The following is a description of a gene set: Human monocyte derived dendritic cells matured via galectin-1 or LPS. species: Homo sapiens Human Gene Set: GSE4984_GALECTIN1_VS_VEHICLE_CTRL_TREATED_DC_DN from publication Fulcher JA, Hashimi ST, Levroney EL, Pang M, Gurney KB, Baum LG, Lee B (PMID 16785517) Genes down-regulated in monocyte-derived dendritic cells: LGALS1 versus vehicle., and this is the list of marker genes: TMEM209, ALMS1P1, ROMO1, ZNF444, EMC2, DONSON, IMMT, ADAM17, MIR21, WDR1, UBALD2, TFRC, PRDM6, ZC3H4, AACSP1, ABAT, ALDH9A1, DUSP10, NR2F6, PIGP, ACOXL (acyl-CoA oxidase like), CFAP46, ACD, ZEB2, STAT4, MCM3, H2AC17, ULBP2, LSM6, BTBD10, AMMECR1L, STIL, ATAD2, PHF5A, ILK, TXNL1, TPTE2P2, NEFH, CARD9, SPAG5 (NCBI Gene Id 10615), PUS1, MCTS1, DIMT1, KNTC1, TOP3A, CALU, PPA1, ME2, CLIC4, PANK3, TRAFD1, SLC34A1, SHLD1, PPP2R5B, RAD54L, DCAF13, SYNGR3, APTX, CPOX, SEC23IP, UBA6, MRPL14, NAA25, CRYGN, CIAO2B, RSU1P2, POLR3K, MUS81, CCDC97, SPTSSA, CCDC117, SLC39A9, COQ7, SS18, PSMA5, FOSL1, STARD3, IL6ST, ADAM19, APOB, TOMM70, NACC1, HNRNPA2B1, ZDHHC13 (zinc finger DHHC-type palmitoyltransferase 13), TIAM2, SLC35A2, NDUFB5, TFE3 (NCBI Gene Id 8244), HOXC11, GCH1 (NCBI Gene Id 93984), RAB34, CDKAL1, DERL2, THOC6, PSME2, E2F3, FTSJ1, ALG2, LGI3, SRSF10, PPIL1, ALG5, RGMB-AS1, NUP50, PLAGL1, CHAC2, IPO8, DCTN2, TOMM40, GOLGA3, ARL4A, GID4, FLJ40288, PLXNC1, ANK2, KCNK15 (potassium two pore domain channel subfamily K member 15), SPIRE1, APOOL, MCOLN2, GINS4, NDUFV2, MRPL38, THPO, GNL3, LSG1, MAPK8, URGCP, POLD3, SPATC1 (spermatogenesis and centriole associated 1), CAB39, GPT2, SSR1, METTL1, SNHG12, GPN2, RHEB, TMED2 (NCBI Gene Id 10959), CREG1, DBR1, IPPK, MSH2, PPP1R10, ZC3H15, TSG101, MTO1, NOD2, RIMOC1, PANX1, CTR9, PRNP, RCAN1, HPS5, SIRT6, SHC1, SPSB2, UBE2A, KPNA2, MKX, JAM2, RNF212B, C10orf71, SFT2D1, RPN1, MYO16, RPA2, MON1A, MRPL27, SRRD, PEF1, SLC52A2, NSFL1C, SUZ12, DDX1, PARP9 (NCBI Gene Id 83666), CLEC18A, POTEKP, NUP93, AFG3L2, KCTD17, SCFD1, PLAA, ITPR1, IFI16 (NCBI Gene Id 3428), PTGES3, NASP, SEMA3A, HARS1, CCT8, HLTF, LRRC8B, ZRANB3, COG3, SMARCB1, PPID, RBM4B, AK2, GBP4, PEX13, HNRNPAB